Given this list of marker genes Ubqln1, Tirap, Trim3, F2rl1, Flot1, Src, Peli1, Cav1, Tnfaip3, Wdfy1, Ptpn22, Rnf170, Hcfc2, here is a description of the gene set: Mouse Gene Set: GOBP_REGULATION_OF_TOLL_LIKE_RECEPTOR_3_SIGNALING_PATHWAY species: Mus musculus Any process that modulates the frequency, rate, or extent of toll-like receptor 3 signaling pathway.